The following is a description of a gene set: species: Mus musculus The chemical reactions and pathways involving estrogens, C18 steroid hormones that can stimulate the development of female sexual characteristics. Also found in plants. Mouse Gene Set: GOBP_ESTROGEN_METABOLIC_PROCESS, and this is the list of marker genes: Cyp3a41b, Ugt2b36, Cyp1a1, Sult1e1, Schip1, Plekha1, Hsd17b4, Ugt1a7c, Comt, Sult1a1 (sulfotransferase family 1A, phenol-preferring, member 1), Gm2044, Hsd17b8, Hsd17b1 (hydroxysteroid (17-beta) dehydrogenase 1), Dhrs11, Cyp3a41a, Cyp1a2, Star, Hsd17b12, Cyp1b1, Cyp3a16, Ugt2b5, Cyp19a1, Bmpr1b, 2610005L07Rik (NCBI Gene Id 436177), Hsd17b7, Ugt1a1, Chst10, Cyp3a44, Cyp3a11, Hsd17b10, Pdgfra (NCBI Gene Id 231312), Ugt2b35, Sgpl1, Tiparp, Hsd17b2, Ugt2b1